The following is a description of a gene set: studied in species Homo sapiens Human Gene Set: HP_LIMB_MYOCLONUS Limb myoclonus, and this is the list of marker genes: PRRT2, CPLX1, TBC1D24, KCTD17, MECP2, GABRG2, GABRA1, GABRB3, KCTD7, MAPT, KCNQ3, DRD2, CACNA1H, PRDX3, CDKL5, PRNP, SMC1A, ASAH1, ABCD1, GABBR2, SCN8A, SLC2A1, TOR1A, SGCE, JRK, NTNG1, SCN2A, KCNQ2, NOP56